The following is a description of a gene set: Hepatocellular carcinomas (HCCs) are a heterogeneous group of tumors that differ in risk factors and genetic alterations. We further investigated transcriptome-genotype-phenotype correlations in HCC. Global transcriptome analyses were performed on 57 HCCs and 3 hepatocellular adenomas and validated by quantitative RT-PCR using 63 additional HCCs. We determined loss of heterozygosity, gene mutations, promoter methylation of CDH1 and CDKN2A, and HBV DNA copy number for each tumor. Unsupervised transcriptome analysis identified 6 robust subgroups of HCC (G1-G6) associated with clinical and genetic characteristics. G1 tumors were associated with low copy number of HBV and overexpression of genes expressed in fetal liver and controlled by parental imprinting. G2 included HCCs infected with a high copy number of HBV and mutations in PIK3CA and TP53. In these first groups, we detected specific activation of the AKT pathway. G3 tumors were typified by mutation of TP53 and overexpression of genes controlling the cell cycle. G4 was a heterogeneous subgroup of tumors including TCF1-mutated hepatocellular adenomas and carcinomas. G5 and G6 were strongly related to beta-catenin mutations that lead to Wnt pathway activation; in particular, G6 tumors were characterized by satellite nodules, higher activation of the Wnt pathway, and E-cadherin underexpression. CONCLUSION: These results have furthered our understanding of the genetic diversity of human HCC and have provided specific identifiers for classifying tumors. In addition, our classification has potential therapeutic implications because 50% of the tumors were related to WNT or AKT pathway activation, which potentially could be targeted by specific inhibiting therapies. Human Gene Set: BOYAULT_LIVER_CANCER_SUBCLASS_G3_DN Down-regulated genes in hepatocellular carcinoma (HCC) subclass G3, defined by unsupervised clustering. studied in species Homo sapiens from publication Boyault S, Rickman DS, de Reyniès A, Balabaud C, Rebouissou S, Jeannot E, Hérault A, Saric J, Belghiti J, Franco D, Bioulac-Sage P, Laurent-Puig P, Zucman-Rossi J (PMID 17187432), and this is the list of marker genes: ZCCHC24, TNXA, FMO4, COL18A1 (NCBI Gene Id 80781), CD302, GGCX, CA5A, PRG2, TNS2, SELENBP1, CRYL1, TMEM204, SERPING1, SLC38A3, TMPRSS6, TF, MTARC2, ASGR2, GAMT, CPN2, TMEM176B, SORBS2, PIK3R1, TST, IFIT1, CYP27A1, ACADVL, SMARCA2, FXYD6, ACAT1, DHTKD1, COX7A1, ALDH5A1, SLC2A2, ECHS1, MASP1, TTC38, ALAD, PCSK6, CPB2, SERPINF1, KNG1, SARDH, F7 (NCBI Gene Id 14068), GPLD1, GIMAP5, CFH, APLNR, MGMT, RARRES2, SLC25A20, MAT2A, PON1